Given this list of marker genes RFX5, CIITA, RFXAP, IL21R, RFXANK, here is a description of the gene set: Chronic hepatitis associated with infection by cryptosporidia, as demonstrated (for example) by immunohistochemistry of liver tissue. studied in species Homo sapiens Human Gene Set: HP_CHRONIC_HEPATITIS_DUE_TO_CRYPTOSPORIDIUM_INFECTION Chronic hepatitis due to cryptosporidium infection